The following is a description of a gene set: from publication Rickman DS, Millon R, De Reynies A, Thomas E, Wasylyk C, Muller D, Abecassis J, Wasylyk B (PMID 18679425) Up-regulated genes that vary between HNSCC (head and neck squamous cell carcinoma) groups formed on the basis of their level of pathological differentiation: moderately vs poorly differentiated tumors. Propensity for subsequent distant metastasis in head and neck squamous-cell carcinoma (HNSCC) was analysed using 186 primary tumours from patients initially treated by surgery that developed (M) or did not develop (NM) metastases as the first recurrent event. Transcriptome (Affymetrix HGU133_Plus2, QRT-PCR) and array-comparative genomic hybridization data were collected. Non-supervised hierarchical clustering based on Affymetrix data distinguished tumours differing in pathological differentiation, and identified associated functional changes. Propensity for metastasis was not associated with these subgroups. Using QRT-PCR data we identified a four-gene model (PSMD10, HSD17B12, FLOT2 and KRT17) that predicts M/NM status with 77% success in a separate 79-sample validation group of HNSCC samples. This prediction is independent of clinical criteria (age, lymph node status, stage, differentiation and localization). The most significantly altered transcripts in M versus NM were significantly associated to metastasis-related functions, including adhesion, mobility and cell survival. Several genomic modifications were significantly associated with M/NM status (most notably gains at 4q11-22 and Xq12-28; losses at 11q14-24 and 17q11 losses) and partly linked to transcription modifications. This work yields a basis for the development of prognostic molecular signatures, markers and therapeutic targets for HNSCC metastasis. Human Gene Set: RICKMAN_TUMOR_DIFFERENTIATED_MODERATELY_VS_POORLY_UP species: Homo sapiens, and this is the list of marker genes: IPO5, DUSP3, ARL8B, ABHD5, ENSG00000291149, BEND3, ORC1, ZNF286A, CPM, ZNF469, NPDC1 (NCBI Gene Id 56654), PRMT1, RAB3D, SRSF3, BSPRY, ARF4, DPYD, SH3BGRL3, SRPX2, SNRPA1, PGLS, TOM1, PAFAH2, MFSD8, CHCHD10, E2F3, CELF1, AP1M2, R3HDM4, ARHGAP32, GLT8D1, SLC44A2, ADCY7, GLT8D2, C1QTNF3, ECM2, SNX19, TRIP11, SLITRK6, VLDLR, EMG1, FANCI, GPR161, VAMP4, ENTPD3, ABHD14A, COL3A1 (NCBI Gene Id 1281), HEATR5A, TMPRSS4, BOK, ADAM12, SNX24, RAB11FIP1 (RAB11 family interacting protein 1), RPS15A, CMTR1, TLR2, MRM3, MFRP, CCNF, RAMP1, VAT1, SLC12A6, POP4, PPIC, KNTC1, EIF2S2, NBL1, FUS, MAFK, KDELR3, LRRC15, YIPF2, IL13RA1, GLB1, TEDC2, GALNT10, IMPDH1, SVEP1, NECTIN4, PRKCH, CPEB4, C19orf48P, SYTL2, SRSF2, SNRPA, IRAK4, CHMP2B, IDS (NCBI Gene Id 3423), S100A6, FUT11, STX12, TACSTD2, CTSK, NCAPG, RPUSD2, COL5A2, ATP6V0E1, LIPH, NR1D1, CPZ, PHACTR2, SH3GLB1, SH3PXD2B, NSF, HDGFL3, NAGA, ANXA2R, NAT10, DENND1B (DENN domain containing 1B), YPEL5 (NCBI Gene Id 51646), OLFML2B, FBN1, MARCHF2, OCEL1, MAN2A1, B3GNT9, GPR160, ADAMTS2, ANAPC1 (anaphase promoting complex subunit 1), DNASE1L1, TRAK1, SIAE, CARD6, CDC25C, MXRA5